Given this list of marker genes Epor, Stat5b, Jak2, Kit, Epo, here is a description of the gene set: The series of molecular signals initiated by erythropoietin (EPO) binding to the erythropoietin receptor (EPO-R) on the surface of a target cell, and ending with the regulation of a downstream cellular process, e.g. transcription. species: Mus musculus Mouse Gene Set: GOBP_ERYTHROPOIETIN_MEDIATED_SIGNALING_PATHWAY